Given this list of marker genes BPGM, EGLN1, EPOR, EPAS1, JAK2, EPO, VHL, HBB, HBA2, SH2B3 (SH2B adaptor protein 3), HBA1, here is a description of the gene set: studied in species Homo sapiens Increased hematocrit Human Gene Set: HP_INCREASED_HEMATOCRIT An elevation above the normal ratio of the volume of red blood cells to the total volume of blood.